The following is a description of a gene set: The process in which a relatively unspecialized cell acquires specialized features of an epithelial cell of the prostate gland. Human Gene Set: GOBP_EPITHELIAL_CELL_DIFFERENTIATION_INVOLVED_IN_PROSTATE_GLAND_DEVELOPMENT studied in species Homo sapiens, and this is the list of marker genes: AR, TP63, STAT5A, NOTCH1, WDR77, HOXB13, FEM1B, PSAP, PSAPL1, FGFR2, FOXA1, CTNNB1